Given this list of marker genes HTR1A, SSTR4, MTNR1A, OPRM1, MC5R, SSTR5, SSTR2, NPY, AGTR2, OPRD1, VIPR1, PTH1R, TSHR, MC1R, MC2R, HTR2A, CHRM4 (cholinergic receptor muscarinic 4), LPAR3, HTR5A, XCR1, CNR1, HRH1, ANXA1, CHRM2, HTR6 (NCBI Gene Id 92230), HTR1D, HRH3, HTR1B, HTR2C, HTR4, CHRM1, SSTR1, HTR2B, HRH2, CCR1, PTGIR, CHRM3, GALR3, CCL2, HTR7, DRD1 (NCBI Gene Id 1812), AGT, DRD4, NPY1R, OR10J5, MC3R, ADRB3, MTNR1B, HTR1F, LHCGR, SSTR3, CALCRL, CNR2 (NCBI Gene Id 1269), CHRM5, HTR1E, HRH4, here is a description of the gene set: studied in species Homo sapiens A G protein-coupled receptor signaling pathway in which the signal is transmitted via the activation or inhibition of a nucleotide cyclase activity and a subsequent change in the concentration of a cyclic nucleotide. Human Gene Set: GOBP_G_PROTEIN_COUPLED_RECEPTOR_SIGNALING_PATHWAY_COUPLED_TO_CYCLIC_NUCLEOTIDE_SECOND_MESSENGER